Given this list of marker genes Dlx3, Ppfia2 (protein tyrosine phosphatase, receptor type, f polypeptide (PTPRF), interacting protein (liprin), alpha 2), Pcnx1, Ephb2, Ptprb, Tcte2, Cul1 (cullin 1), Scai, Pam, Pwwp2a, Eed, Maob, Bicd1, Kcnv2, Ints6l, Shisa6, Jun, Zdhhc15, Nfasc, Tmem68 (NCBI Gene Id 99971), Ehd1 (EH-domain containing 1), Uhmk1, Med13l, Pold3, Abca1, Rasgef1a, Adcy9, Elavl2, Itpr1, Zfp984 (zinc finger protein 984), Cers2, Dlc1, Sesn1, Psmb2, Apaf1, Sft2d2, Ptprt, Tmtc2 (NCBI Gene Id 66807), Gosr1, Gm13288, Fgf11, Parn, Traf3, Pde12 (phosphodiesterase 12), Dnajc11, Yipf5, Tcf7l2, Zfp704, Zfp804a, Acly, Dpysl2, Abl2, Ctr9, Aqp9, Stk40, Spef2, Myt1l, Zfp827, Zfp747l1, Pole3, Nudcd1, Col1a2, Gab2, Dnajb2, Ctla4, Ubl4a, Ccdc88b, Fgl2, Bach1, Fbxo46, Dnase1 (deoxyribonuclease I), Zfp979, Tmem71, Usp33, Ush2a, Dyrk1a, Calcrl, Afg2a, Kcna1, Senp2, Zfyve16, Smyd1, Ndrg2, Rmnd5a, Abi2, Pabpc6, Plxnc1, Midn, N4bp1, Arl13b, G3bp2, Ormdl1, Ets1, Psat1, Acot7, Uncx, Trim37, Amotl2 (NCBI Gene Id 97534), Zfp985, Gapvd1, Tnfrsf11b, Jazf1, Lrr1, Zfp148, Zfp268, Zfp1005, Calm1, Syt15, Mrps18b, Ufc1, Akap6, Taok1, Clcnka (chloride channel, voltage-sensitive Ka), Arih1, Kctd17, Prickle1, Thsd7b, E2f3, Skap2, Peg10 (NCBI Gene Id 30899), Tspan13, Nbea, Spin1, Tmbim7, Myo1b, Fcer1g, Hspa2, Ikzf3, Tmx4, Fam168a, Pdcd7, Gdpd5, Mfn1, Armc8, Sinhcaf, Zfp600, Atf7ip2, Sec24d, Gdf5, Ndrg3, Usp27x, Dtna, Egfl7 (NCBI Gene Id 353156), Tnrc6b, Gtf2e1, Tet2, Col8a2, Hccs, Unc5c, Nup54, Mapk10, Fry, Rimbp2, Suclg1, Slc39a10, Rab11fip3, Nav2, Eif2s1, Agfg1, Pira2, Larp4, Dguok, Rab23, Brd7, Zfp981, Rex2, Rgs8, Deup1, Cnr1, Suz12, Celf6, Cnnm3, Fam114a1, Slc25a24, Gria3, Podn, Limk2, Glce, Gpt2, Rpn2, Recql, D8Ertd738e, Zfp980, Gas2l3, Celf4, Cst7, Pudp, Spag11b, Gga2 (NCBI Gene Id 74105), Zfp395, Sostdc1, Dcbld1, here is a description of the gene set: from publication Chen Y, Wang X (PMID 31504780) studied in species Mus musculus Mouse Gene Set: MIR_693_3P Genes predicted to be targets of miRBase v22 microRNA mmu_miR_693_3p in miRDB v6.0 with MirTarget v4 prediction scores > 80 (high confidence targets).